Given this list of marker genes SMAD2, BMP4, SMAD1, METTL3, SRSF3, IL6 (NCBI Gene Id 3569), DDX5, STAT3, PUS10, LIN28B, SRRT, TGFB1, HNRNPA2B1, DGCR8, NCBP2, NCBP1, DROSHA, SMAD3, here is a description of the gene set: A process involved in the conversion of a primary microRNA transcript into a pre-microRNA molecule. species: Homo sapiens Human Gene Set: GOBP_PRIMARY_MIRNA_PROCESSING